Given this list of marker genes ROR1, COL1A2, GSE1, GPR176, TSC22D2, ATRN, BICD1, CCND1, SERPINB2, DST, INTS3, PIK3C2A, GPATCH8, MPHOSPH9, AMPH, TOP1, SLC16A7, MAD1L1, KLHL20, LRP6, RBPMS, PHF14, BTAF1, FAM193A, HEG1, TOGARAM1, AGO2, CREB5, CTIF, MITF, AHDC1, GALK2, UBXN7, TEAD1, ACVR2A, TMCC1 (transmembrane and coiled-coil domain family 1), EIF3A, PLPP3, ARHGEF10, UST, TMEM131L, MSH3, RALGAPB, SMAD7, PDS5B (PDS5 cohesin associated factor B), DOCK9, SYNJ2, PEX14, NFIB, FAM168A (NCBI Gene Id 23201), VPS13B, PLCE1, NECTIN3, PTPRM, SON, MALT1, CDKN1B, ATXN1 (NCBI Gene Id 7912), ACAP2, HERC4, USP15, WDHD1, DOCK4 (dedicator of cytokinesis 4), RB1CC1 (RB1 inducible coiled-coil 1), ZFHX3, PCNT, SFMBT1, ITCH, NALF1, ZEB2, WDR37 (NCBI Gene Id 22884), AVL9, SGMS1, NAV3, ASXL1, SKAP2, HAS2, MIA2, ARAP2, TRIM24, CDC42BPA, DNAJC2, DMD, LPAR1, here is a description of the gene set: Human Gene Set: DACOSTA_UV_RESPONSE_VIA_ERCC3_TTD_DN from publication da Costa RM, Riou L, Paquola A, Menck CF, Sarasin A (PMID 15608684) species: Homo sapiens Genes exclusively down-regulated in fibroblasts expressing the TTD mutant form of ERCC3, after UVC irradiation. Xeroderma pigmentosum (XP) and trichothiodystrophy (TTD) syndromes are characterized by deficiency in nucleotide excision repair pathway, but with distinguished clinical manifestations. While XP patients exhibit a high frequency of skin cancer, TTD patients are not cancer prone. The relation between lack of DNA repair and their clinical manifestations was investigated through analysis of the transcriptional profile of 12,600 transcripts in two isogenic cell lines with different capabilities of DNA repair. These cell lines result from a stable transfection of the XPB-TTD allele into XP complementation group B fibroblasts, from an XP patient who also have clinical abnormalities corresponding to Cockayne's syndrome (CS). The microarray assays performed under normal growth conditions showed the expression of distinct groups of genes in each cell line. The UVC-transcription modulation of these cells revealed the changes in 869 transcripts. Some of these transcripts had similar modulation pattern in both cells, although with eventually different time patterns for induction or repression. However, some different 'UVC signature' for each cell line was also found, that is, transcripts that were specifically UV regulated depending on the DNA repair status of the cell. These results provide a detailed portrait of expression profiles that may potentially unravel the causes of the different phenotypes of XP/CS and TTD patients.